The following is a description of a gene set: The binding activity of a molecule that functions as a physical support for the assembly of a multiprotein mitogen-activated protein kinase (MAPK) complex. Binds multiple kinases of the MAPKKK cascade, and also upstream signaling proteins, permitting those molecules to function in a coordinated way. Bringing together multiple enzymes and their substrates enables the signal to be transduced quickly and efficiently. Mouse Gene Set: GOMF_MAP_KINASE_SCAFFOLD_ACTIVITY species: Mus musculus, and this is the list of marker genes: Spag9, Pxn (NCBI Gene Id 19303), Mapk8ip1, Akap13, Ksr2, Iqgap1, Ksr1, Map2k1, Sh3rf1, Mapk8ip3, Mapk8ip2, Dusp19, Map2k2